The following is a description of a gene set: A group of parasomnias that occur during the transition from wakefulness to sleep or from one sleep stage to another. Rhythmic Movement Disorder, Sleep Starts, Sleep Talking, and Nocturnal Leg Cramps - these four disorders belong to Sleep-Wake Transition Disorders in the International Classification of Sleep Disorders. Disturbance during transitions between sleep and wake states studied in species Homo sapiens Human Gene Set: HP_DISTURBANCE_DURING_TRANSITIONS_BETWEEN_SLEEP_AND_WAKE_STATES, and this is the list of marker genes: P2RY11, HCRT, DEPDC5, CHRNA4, HLA-DQB1, CHRNB2, CRH, MOG, HLA-DRB1, CABP4, DNMT1, TRANK1, SIM1, KCNT1, MAGEL2, TNFSF4, CTSH, ZNF365, CHRNA2